The following is a description of a gene set: Neighborhood of MYCL1 Neighborhood of MYCL1 v-myc myelocytomatosis viral oncogene homolog 1, lung carcinoma derived (avian) in the GCM expression compendium studied in species Homo sapiens Human Gene Set: GCM_MYCL1, and this is the list of marker genes: APOC3, EBI3, HMGA2, FUT2, AQP7, AVPR1B, NDUFA1, KRT35, IKBKE, MPP2, MYCL, ZNF8, IRF5, UROD, BNIP1 (NCBI Gene Id 662), DRG2, ASMT, KRT83, HMGXB3, MVK, GRM4, CCL2, TMEM106A, ADCYAP1, BCAT2